The following is a description of a gene set: Genes down-regulated in T cells from CLL (chronic lymphocytic leukemia) patients: CD4 versus CD8. Human Gene Set: GSE8835_CD4_VS_CD8_TCELL_CLL_PATIENT_DN To examine the impact of tumors on the immune system, we compared global gene expression profiles of peripheral blood T cells from previously untreated patients with B cell chronic lymphocytic leukemia (CLL) with those from age-matched healthy donors. Although the cells analyzed were not part of the malignant clone, analysis revealed differentially expressed genes, mainly involved in cell differentiation in CD4 cells and defects in cytoskeleton formation, vesicle trafficking, and cytotoxicity in CD8 cells of the CLL patients. In coculture experiments using CLL cells and T cells from healthy allogeneic donors, similar defects developed in both CD4 and CD8 cells. These changes were induced only with direct contact and were not cytokine mediated. Identification of the specific pathways perturbed in the T cells of cancer-bearing patients will allow us to assess steps to repair these defects, which will likely be required to enhance antitumor immunity. Gene expression profiling was performed to determine whether CLL cells induce changes in T cells in patients with CLL. studied in species Homo sapiens from publication Görgün G, Holderried TA, Zahrieh D, Neuberg D, Gribben JG (PMID 15965501), and this is the list of marker genes: GPX3, ADGRG5, PLXNB3, UEVLD, CARD11, LTBP3, GAS7, DPP4, DTX4, MMP9, PLXDC2, ADAMDEC1, LOXL3, TIMM21, HOXB5, RNF122, ANXA3, CCL24, OSGIN1, PAQR4, PTGS1, TBC1D8, SYK, RETREG1, RGS1, POGLUT2, AMZ1, FAM217B, TMEM176B, FCGR2A, CRPPA, ACAD10, CAMKK1, ZNF691, IL1RL2, BBS9, HFE, S100PBP, CLMP (CXADR like membrane protein), NDST1, MYO1A, PTCH1, VPS41, NUDT16L1, EVC2, CD81, MSRB2, SLC25A10, MRGPRE, CD163, OCSTAMP, TMEM273, LRP6, CX3CR1, CHKB, C3orf70, ZMPSTE24, MDP1, BLTP3A, DKK3, DNAJC16, SLC25A26, CTSF, BBS5, APOE, SAMD10, DAB2IP, HLA-DRB1, DEPTOR, STAB1, PTGER2, F11R, CALHM4, TREML4, DALRD3, OPLAH, PTER, PCDHB3, TSC2, RTCB, MYMK, KLHL6, COL13A1, WTIP, SNX24, PGF, MAGED1, BMP2, RCN3, ITGB5, PLA2G7, RAI1, CBR3, ALDH1A1, FBP1, ELMOD3, EXTL1, LPCAT2, TNFSF13B, PDE1B, CBL, ADAM22, RCBTB2, TBC1D12, NUSAP1, YPEL3, KYNU, EIF2B2, KITLG, GALNT3, TMEM71, GDPD1, POMT1, SMAD6, RPN1, CNRIP1, RASAL3, WBP1L, ANTXR2, BANK1, SGSH, LGI2, MEIS3, FOXF2, KLHL13, NTPCR, SC5D, CCDC102A, ITGA9, SULT1A1, MGAT4A, FCGRT (NCBI Gene Id 2217), WDR90, ZNF436, HIC1 (NCBI Gene Id 3090), CRACDL, CTC1, C7orf25, B9D1, ALDOC, EMC9, TBXAS1, SMYD4, SUSD1, CIITA, TRRAP, FAM20C, CRTC3, TSPAN33, MMD, TMEM191C, SORL1, TACC2, ATP6V0D2, HACD4, CYP2J2, PLBD1, NPL, PILRA, LIPA, ZDHHC14, RGL2, ATP6V0E2, EMILIN1 (NCBI Gene Id 25883), HRH1, CADM1, NUAK1, SMIM3, KLHDC10, DMXL2, KHK, SLC39A11, IRF6, SLCO2B1, PELI2 (NCBI Gene Id 93480), RAD51B, COL14A1, CD33, FMO5, MARVELD2, TBC1D16, RNASE4, MSMO1, DIP2C, SLC12A5, TRAF3IP3, ACYP1 (NCBI Gene Id 97), LUM, MYOM1 (myomesin 1), OLFML3 (olfactomedin like 3), TENM4, IQGAP3, CCL11, MAN2A2 (mannosidase alpha class 2A member 2), URI1, ADAT2, SERPINB8, TMEM141 (NCBI Gene Id 85014), PCGF6, SLC30A4